The following is a description of a gene set: from publication Mariadason JM, Corner GA, Augenlicht LH (PMID 10969808) The short-chain fatty acid butyrate, produced by microbial fermentation of dietary fiber in the large intestine, is a physiological regulator of major pathways of colonic epithelial cell maturation: cell cycle arrest, lineage-specific differentiation, and apoptosis. Microarray analysis of 8,063 sequences demonstrated a complex cascade of reprogramming of SW620 colonic epithelial cells upon treatment with butyrate characterized by the progressive recruitment of gene sets as a function of time. Comparison with the effects of trichostatin A, in conjunction with differences in the kinetics of alteration of histone acetylation induced by butyrate and trichostatin A, identified subsets of induced and repressed genes likely coordinately regulated by altered histone acetylation. The butyrate response was also compared in detail with that of sulindac, a nonsteroidal anti-inflammatory drug with significant chemopreventive activity for colon cancer, and curcumin, a component of mustard and curry structurally and functionally related to sulindac that also has chemopreventive activity. Although gene clusters were identified that showed similar responses to butyrate and sulindac, the data were characterized by the extensive differences in the effects of the two agents. This was striking for functional classes of genes involved in signaling pathways and in cell cycle progression, although butyrate and sulindac induce a similar G0-G1 arrest, elevation of beta-catenin-Tcf signaling, and apoptotic cascade. As regards cell cycle arrest, the underlying mechanism in response to butyrate was most similar to that of the Caco-2 cell line that had spontaneously undergone a G0-G1 arrest and least similar to the G2-M arrest stimulated by curcumin. Thus, high-throughput microarray analysis of gene expression profiles can be used to characterize and distinguish the mechanisms of response of colonic epithelial cells to physiological and pharmacological inducers of cell maturation. This has important implications for characterization of chemopreventive agents and recognition of potential toxicity and synergies. The data bases, gene clusters, and analyses are available at http:// sequence.aecom.yu.edu/genome/. Cluster 8: genes down-regulated in SW260 cells (colon cancer) by sodium butyrate, curcumin, sulindac and TSA. species: Homo sapiens Human Gene Set: MARIADASON_RESPONSE_TO_BUTYRATE_CURCUMIN_SULINDAC_TSA_8, and this is the list of marker genes: TBC1D23, HNMT, PPIL6, ZNF148, SOS2, A1CF, CREM, MTDH, PI4KAP1, CALML4